The following is a description of a gene set: studied in species Homo sapiens Genes predicted to be targets of miRBase v22 microRNA hsa-miR-7113-5p in miRDB v6.0 with MirTarget v4 prediction scores > 80 (high confidence targets). Human Gene Set: MIR7113_5P from publication Chen Y, Wang X (PMID 31504780), and this is the list of marker genes: WNT3A, REPIN1, FRMD8, FAM86C1P, PPP1R16B, NSL1, NFASC, VPS39, ELK1, GABRB1, FXN, FAM86B1, CIMIP6, USP42, ZNF785, RAB43, SLC36A1, VANGL1, PROZ, DGKI, PLEKHM3, MAML2, CTNND1, ZNF829, TRAPPC9, LCE1C, OCEL1, WDTC1, SEMA4F, PRR15L, RASGRP4, USP46, TBC1D7, CASTOR2, COL5A1, ARHGDIA, SYNM (NCBI Gene Id 23336), FIBCD1, CHTF8, STIM1, ROCK2, MTCL2, TMEM120B, ANTXR1, UBL4B, TMEM106A, FAM13A, DACT3, MCM6, PNRC1, MICAL2, DPP6, SEPTIN3, XIRP1, RBFA, TRIM25, CPN2, RAB28, ISY1-RAB43, CPEB3, SSPN (sarcospan), DDI1, LINGO2, FEM1A, CTNNBIP1 (NCBI Gene Id 56998), B3GNT3, AP4B1, CARTPT, LINC02898, ZNF521, R3HDM2 (NCBI Gene Id 51220), HROB, SLC25A23, DNAAF5, MMRN2, TNKS1BP1, FRAT1 (NCBI Gene Id 10023), GAS7, MAP4, APLP1, MR1, KPNA6 (karyopherin subunit alpha 6), ZWINT, TMEM132B, CLU, PKNOX2, ETHE1, ARF3, DDB1, VDAC3, NEIL2, ZMIZ2, PRDM8, SORCS2, DPP10, MLEC, SYT9, TGM5, IQSEC2, FERMT1, ZBTB4, ATP5MG, ARHGAP31, MAGEA10, ZNF512B, PLXNA4, RORC, MPL, TBC1D16, HVCN1 (NCBI Gene Id 84329), SVIP, LYPLA2, MPRIP, LYPD6, LRRC20 (leucine rich repeat containing 20), CHRNE, ZFYVE27, SCD, PLXDC1, PNMA8B, SHPK, HEMK1, TNFRSF11A, MS4A4A, ANO1, TMSB15B, PITPNM3, PACS2, DHX8, RAP1A, CCDC6 (NCBI Gene Id 8030), ASPH, BAHCC1, ARHGAP35, SIGLECL1, HSPB8, AMER2, CNNM4, AHCYL2, ZDHHC5, CADM3, PSMD9, NCOA2, C1orf115, IQSEC3, BEND2, PNPO, TMEM37, SUMF2, CSF1 (colony stimulating factor 1)